Given this list of marker genes NUBPL, IKBKB, RPL34, SRGN, NFIL3, TMEM59L, IRX3, KDELR3, MAP1LC3A, FLNC, TTC16, LHX1, ZIM2, ZNF367, SIK1, PPARGC1B, HHIP, CLCN3 (chloride voltage-gated channel 3), GRP, GPBP1, CCN1, SLC44A4, DNAJB11, UFC1, TACR1, NINJ1, PNPLA3, IDH3G, SLC25A25, CHGB, MARCKS, HDLBP, ITFG2, TSC22D2, DUSP4, SH2D2A, PAK1, CDX4, FSTL5, UCN, SGK1, TRIM39, GK, CNTROB (NCBI Gene Id 116840), LRRTM1 (leucine rich repeat transmembrane neuronal 1), DDX51, CALD1, PPM1A, NUP42, OSR1, PDLIM3, GART, C1orf21, FAM131A, CYSTM1, DCTN1, SEC62, TMEM147, DAAM2, TAOK2, ETF1, AAMP, CD2AP, GNG4 (NCBI Gene Id 2786), CLSTN3, NCALD, SON, FOXRED1, GPM6B, LRP1, HOXC10, PNMA3, ING3, NOL4, LMO4, TH, TBC1D32, OGDH, CEP57, EGR3, NSD3, RCE1, RNF44, SLC35F5, WFDC3, RPL34-DT, DNAJB2, MAP3K13, LGR5, RAB24, PNMA6A, MAFF, CLDN6, PRR3, SLC7A3, EVX1, SEC61A1, RAB3A, GTF2F1, ZFAND5, ZFHX3, FAM76B, ST13, CMSS1, TRA2B, GEM, ASPHD1 (aspartate beta-hydroxylase domain containing 1), SSR4, TIPRL, CYLD, GTF2A1, UBE2B, NDEL1, LCMT1, TRAPPC10, SND1, ZNF516-DT, GOLGB1, KRTCAP2, LUC7L2, GAK, GNL1, SULT4A1, AKIRIN1, PHACTR3, TOP1, SIDT2, TSPAN7, CPNE4, H4C5, ELAVL1, MCAM, PEG3, XPNPEP1, ZNF184 (NCBI Gene Id 7738), DHX36 (DEAH-box helicase 36), SST, LMTK2, PDXDC1, CHPF (NCBI Gene Id 79586), TAF2, MAPK10, BNIP3L, FOSB, EIF1, SLC5A7, UBA6, ICA1, IPO11, ATG5, CDC42, BABAM2 (NCBI Gene Id 9577), STAMBP, SPRED2, PPARGC1A (PPARG coactivator 1 alpha), GNB4, TLE3, ISCU, FGF9, CLDN7, ZZEF1, ATF3, PMEL, PPP1R15A, DDX19A, PRNP, TRIB1, ZNF576, NUP214, ERG28 (ergosterol biosynthesis 28 homolog), SSTR2, MYL6, TRIM46, KCNN2, HS3ST2, TGIF2, KAT5, DRD4, GRM3, ADCY8, MMGT1, DUSP1 (NCBI Gene Id 1843), TMEM39A, SRSF1, CCNA2, LINC00649, ATP6V0C, RAPGEFL1, PRELID1, ZBTB21, GPR3, PNKD, AMER2, CDK2, SLC18A2, EGR4, MBNL2, ERF, C11orf87, ELOVL5, ZFY, CTC1, SGIP1, SRP54, CBX8, HID1, MBNL1, PNRC1, SCG2, VIP, SLC39A5, EGR2, RCAN1, PAFAH1B1, EPHA2, RNF166, RPRD1A, IRX6, RFX1, XPNPEP3, GLYR1, YME1L1 (NCBI Gene Id 115724), AMOTL1, AGPAT4, INTS7, RING1, HS3ST3A1, FGF6, LDAH, USP48, ADCYAP1, NKX2-2, RPS29, FOXD3, NEUROD6, NEDD1, FAM174A, RHOBTB1, HOXD8, CLDN3, PFAS, JUND, SPAG9, IRF2BPL, CHMP4B, RANBP6, NFATC1, SIK2, NF1, TPM4, FOS, JOSD1, RUSC1-AS1, PCDH9, PAMR1, APH1A, PER1, GOLGA2, RUNDC3A, SRPRA, TMEM175, NR4A2, TERF2, LDHA, TBX5, PTPRU, NPTX1, here is a description of the gene set: Genes having at least one occurrence of the motif CNSTGACGTNNNYC in the regions spanning 4 kb centered on their transcription starting sites. This matches the transcription factor binding site V$ATF_01 (v7.4 TRANSFAC). Human Gene Set: ATF_01 species: Homo sapiens